The following is a description of a gene set: Pathway Definition from KEGG: TGFA -> EGFR -> GRB2 -> SOS -> RAS -> RAF -> MEK -> ERK studied in species Homo sapiens Human Gene Set: KEGG_MEDICUS_REFERENCE_TGFA_EGFR_RAS_ERK_SIGNALING_PATHWAY TGFA-EGFR-RAS-ERK signaling pathway. Pathway ID: N00229. Pathway type: Reference. Pathway class: nt06260 Colorectal cancer., and this is the list of marker genes: SOS2, SOS1, ARAF, GRB2, MAPK3, MAP2K2, TGFA (transforming growth factor alpha), HRAS, RAF1 (NCBI Gene Id 5894), MAP2K1, MAPK1, NRAS, BRAF, EGFR, KRAS